The following is a description of a gene set: Conjugated hyperbilirubinemia studied in species Homo sapiens Human Gene Set: HP_CONJUGATED_HYPERBILIRUBINEMIA, and this is the list of marker genes: SLCO1B1, LYN, SLC17A5, IFT56, TNFSF15, VPS33B, ATP8B1, TNPO3, MYO5B, SLCO1B3, PKHD1, INSR, PEX14, ROBO1, AKR1D1, VIPAS39, BAAT, MPV17, SLC25A13, POLG2, IL12RB1, SLC51A, SPIB, HSD3B7, SLC2A1, GLRX5, ABCC2, GBA1 (NCBI Gene Id 82008), POU2AF1, PEX2, MMEL1, UBR1, NR1H4, IARS1, IL12A, IRF5, OTC, ABCB11, TFAM, KIF12